Given this list of marker genes Mtm1, Ube2v2, Sirt2, Socs5, Tlk2, Hspa1b, Axin1, Agtpbp1, Plk3, Pml, Sumo3, Anks1 (NCBI Gene Id 224650), Gba1, Dnajb2, Sufu, Csnk2b, Rad23a, Gsk3a, Ubxn1, Dda1, Hspa1a, E330034G19Rik, Sh3rf3, Rbx1-ps, Tmem168, Gsk3b, Csnk1a1 (NCBI Gene Id 93687), Laptm5, Eif3h, Styx, Ubqln4, Traf7, Rchy1, Wnt1, Csnk1d, Gclc, Csnk1e, Smurf1, Fbxw8 (F-box and WD-40 domain protein 8), Trim67, Ccar2, Fhit, Fbxo22, Hipk2, Commd1 (COMM domain containing 1), Wac, Cop1, Disc1 (disrupted in schizophrenia 1), Nub1, Rybp, Rack1, Ccdc22, Phf20l1, Araf, Bag6, Map1a, Stub1, Trib3, Sirt1, Ogt, Usp7, Herpud1, Fzr1, Svip, Cdc20b, Rpl11, Bag2, Bbs7 (NCBI Gene Id 71492), Rnf180, Klhl40, Nop53, Il33, Qrich2, Cbfa2t3, Usp38, Cdc20, Atg7, Rpl5, Taf9, Sumo2, Ube3a, Cdkn2a, Rnf139, Socs4, Mapk9, Zfp418, Styx-ps (NCBI Gene Id 100040244), Trim39, Clec16a, Gna12, Mdm2, Xpo1, Trf, Trib1 (tribbles pseudokinase 1), Foxf2, Ptk2b, Usp14, Psen2, Rps7, Dab2, Lrrk2, Rpl23, Shh, Rbx1, Dvl1, Ddrgk1, Prickle1 (NCBI Gene Id 68784), Zyg11b, Usp26, Sumo1, Uchl5, Hfe, Gabarap, Mapk8, Caml, Hsp90ab1, Agbl4, N4bp1, Zer1, Pten, Hamp, Clu, Usp9x (ubiquitin specific peptidase 9, X chromosome), Cdk5rap3, Ptk2, Pbk, Chfr, Csnk2a2, Rybp-ps, Psmd10, Ttc36, Wnt10b, Tgfb1i1, Sgta, Hspbp1, Rad23b, Plk2, Pias1, Desi1, Vcp, Det1, Prkn, Lats1, Usp5, Senp1, Axin2, Pdcl3, Ufl1, Psen1, Atxn3, Egf, Smarcc1, Bag5, Prmt6, Gipc1, Nkd2 (naked cuticle 2), L3mbtl3, Sirt6, Paqr3, Glmn, Trib2, Sh3rf2, Fbxw7, Pabir1, Mtor, Sh3rf1, Aurka (NCBI Gene Id 99385), Bcap31, Plk1, Ube2k (ubiquitin-conjugating enzyme E2K), Park7, Zfand2a, Akt1, Pabpn1l, here is a description of the gene set: Any process that modulates the frequency, rate or extent of ubiquitin-dependent protein catabolic process. Mouse Gene Set: GOBP_REGULATION_OF_UBIQUITIN_DEPENDENT_PROTEIN_CATABOLIC_PROCESS studied in species Mus musculus